The following is a description of a gene set: Human Gene Set: HP_SLOW_DECREASE_IN_VISUAL_ACUITY Slow decrease in visual acuity studied in species Homo sapiens, and this is the list of marker genes: DNAJC30, TRAF7, BRAF, SUFU (SUFU negative regulator of hedgehog signaling), MT-ND6, BAP1, TGFBI, SMO, FA2H, MT-ND5, MT-ND1, MT-ND4L, NF2, GUCY2D, RAX2, SMARCB1 (NCBI Gene Id 6598), MT-CO3, TERT, DNM1L (NCBI Gene Id 692222), MT-CO1, SMARCE1, CTNNB1, MT-ATP6, MT-ND2 (mitochondrially encoded NADH:ubiquinone oxidoreductase core subunit 2), NDUFS2, MT-ND4, AKT1, MT-CYB, MFN2, RP1L1, GUCA1A, PRPH2, PDGFB, PIK3CA (NCBI Gene Id 5290)